The following is a description of a gene set: The series of molecular signals initiated by the binding of the cell surface receptor CD27 to its physiological ligand CD70, and ending with the regulation of a downstream cellular process, e.g. transcription. studied in species Homo sapiens Human Gene Set: GOBP_CD27_SIGNALING_PATHWAY, and this is the list of marker genes: LCK, PTPN6, CD70, CD27, TRAF2